Given this list of marker genes TMEM245, ABCB11, DSG1, SLC22A4, GRK3, H2AC8, TTPA, NUDT6, FAM169A, SLC4A4, SLC16A1, ALDH3A2, RTP3, HSDL2, DYNC1I1, MYRIP, ADH6, SEC14L2, SMPX, REG3A, FGF13, TNFRSF19, BAMBI, ACSM3, INSIG2, SPARCL1, DPP4, FRMD3, AXIN2, SLC17A1, PRAG1, ACSS3 (acyl-CoA synthetase short chain family member 3), CTNNBL1, C3orf85, HOGA1, AOX1, ACE2, IRX3, BHLHE40, SPRYD7, SULT1B1, THBS4, GSTM2, VEGFD, KCNK1, HSD11B1, CDC14B, AQP6, EXPH5, ADRB2, ZNF385B, GPAM, PHLPP1, SALL1, SLC22A11, TMEM150C, ASAP2, EBPL, GPHN (gephyrin), UBXN10, HLF, PANX1, TBCK, MTHFD1, BMP4 (NCBI Gene Id 652), ZNRF3, BIK, FIRRM, SELENBP1, SNAI2, CTNNA2, RUNDC3B, CORIN, TMEM100, LGR5, HIBADH, BOK, AQP11, HEPACAM, PREB, TBX3, PDK1, ACSL5, CST1, SLC16A4, IFT70A, CD36, CYP1A1, PAGE4, VLDLR, FAS, CYP2E1, SLC16A10, WASHC3, TRIB2, SLC25A30, SLCO1B1, NKD1, MAP3K8, TPRG1, SLC16A11, RBP1, CDK6, CLDN2, TTC9, SLC2A12, IRS1, REG1A, PLPPR1, DNAJC12, SLC6A12, MERTK, AR, ITPR2, HABP4, TMEM64, ALDH3A1, ECM2, C1orf53, PDK4, YPEL1 (NCBI Gene Id 94021), SEPTIN4, FITM2, NEK3, ACSL6, PTPRG, MME, CPPED1, TSPAN5, PHYHIPL (NCBI Gene Id 84457), GLYAT, NAGS, EPHB2, CYP8B1, SRD5A2, KCNJ8, AMACR, HTR2B, CAVIN2, ABCG2, ACTN2, UST, SHLD2, AADAC, SLC47A1, PRR5L, RHBG, ANKFN1, FAM3B, GNAI1, SLC5A6, CCDC170, ESRRG (estrogen related receptor gamma), RAB11FIP2, RHOBTB1, AQP9, HPD, ALDH1L1, GFRA1, SLC13A3, TAPT1-AS1, ABHD6, SLC1A2 (solute carrier family 1 member 2), CAP2, PLAAT2, HHAT, GRHPR, CRLS1, ASPSCR1, NUBPL, GLUL, FAM8A1, TENM2, DCXR, C20orf204, here is a description of the gene set: Human Gene Set: CHIANG_LIVER_CANCER_SUBCLASS_CTNNB1_UP Top 200 marker genes up-regulated in the 'CTNNB1' subclass of hepatocellular carcinoma (HCC); characterized by activated CTNNB1. studied in species Homo sapiens from publication Chiang DY, Villanueva A, Hoshida Y, Peix J, Newell P, Minguez B, LeBlanc AC, Donovan DJ, Thung SN, Solé M, Tovar V, Alsinet C, Ramos AH, Barretina J, Roayaie S, Schwartz M, Waxman S, Bruix J, Mazzaferro V, Ligon AH, Najfeld V, Friedman SL, Sellers WR, Meyerson M, Llovet JM (PMID 18701503) Hepatocellular carcinomas represent the third leading cause of cancer-related deaths worldwide. The vast majority of cases arise in the context of chronic liver injury due to hepatitis B virus or hepatitis C virus infection. To identify genetic mechanisms of hepatocarcinogenesis, we characterized copy number alterations and gene expression profiles from the same set of tumors associated with hepatitis C virus. Most tumors harbored 1q gain, 8q gain, or 8p loss, with occasional alterations in 13 additional chromosome arms. In addition to amplifications at 11q13 in 6 of 103 tumors, 4 tumors harbored focal gains at 6p21 incorporating vascular endothelial growth factor A (VEGFA). Fluorescence in situ hybridization on an independent validation set of 210 tumors found 6p21 high-level gains in 14 tumors, as well as 2 tumors with 6p21 amplifications. Strikingly, this locus overlapped with copy gains in 4 of 371 lung adenocarcinomas. Overexpression of VEGFA via 6p21 gain in hepatocellular carcinomas suggested a novel, non-cell-autonomous mechanism of oncogene activation. Hierarchical clustering of gene expression among 91 of these tumors identified five classes, including CTNNB1, proliferation, IFN-related, a novel class defined by polysomy of chromosome 7, and an unannotated class. These class labels were further supported by molecular data; mutations in CTNNB1 were enriched in the CTNNB1 class, whereas insulin-like growth factor I receptor and RPS6 phosphorylation were enriched in the proliferation class. The enrichment of signaling pathway alterations in gene expression classes provides insights on hepatocellular carcinoma pathogenesis. Furthermore, the prevalence of VEGFA high-level gains in multiple tumor types suggests indications for clinical trials of antiangiogenic therapies.